Given this list of marker genes ACVR1, CPLANE2, GATA5, TGFB2, TGFBR2 (transforming growth factor beta receptor 2), here is a description of the gene set: Human Gene Set: GOBP_ENDOCARDIAL_CUSHION_FUSION studied in species Homo sapiens The cell-cell adhesion process of mesenchymal cardiac cushion cells that contributes to the process of cushion shaping.